Given this list of marker genes Sox9, Icam1, Sox8 (NCBI Gene Id 20681), Sdc1, Dmrt1, Arid4b, Nr5a2, Map7, Flna, Gata1, Atrx, Fndc3a, Adrm1, Cftr, Sox3, Il1a, Akap9, Abcb1a, Fshr, Fer, Rab13, Arid4a, Ntrk1, Gja1, Hsd17b4, Nup210l, Wt1, here is a description of the gene set: Mouse Gene Set: GOBP_SERTOLI_CELL_DEVELOPMENT The process whose specific outcome is the progression of a Sertoli cell over time, from its formation to the mature structure. Cell development does not include the steps involved in committing a cell to a Sertoli cell fate. species: Mus musculus